Given this list of marker genes INSR, SLC2A2, KCNE3, KCNJ18, GABRA3, CACNA1S, SCN4A, GYS2, SHPK, here is a description of the gene set: Postprandial hyperglycemia An increased concentration of glucose in the blood following a meal. species: Homo sapiens Human Gene Set: HP_POSTPRANDIAL_HYPERGLYCEMIA